The following is a description of a gene set: Human Gene Set: GOBP_POSITIVE_REGULATION_OF_NEUROTRANSMITTER_UPTAKE species: Homo sapiens Any process that activates or increases the frequency, rate or extent of the directed movement of a neurotransmitter into a neuron or glial cell., and this is the list of marker genes: SLC17A8, DRD2, ITGB1, DRD4, PRKN, RAB3B